The following is a description of a gene set: Any process that modulates the frequency, rate or extent of mitochondrial outer membrane permeabilization involved in apoptotic signaling pathway. species: Homo sapiens Human Gene Set: GOBP_REGULATION_OF_MITOCHONDRIAL_OUTER_MEMBRANE_PERMEABILIZATION_INVOLVED_IN_APOPTOTIC_SIGNALING_PATHWAY, and this is the list of marker genes: BOK, GCLC, GSK3A, SLC25A6, BCL2L1, SLC25A4, FZD9 (NCBI Gene Id 8326), TMEM14A, SIVA1, GSK3B, MPV17L, LRRK2, CHCHD10, ATP5IF1, SLC25A31, HSPA1A, ACAA2 (acetyl-CoA acyltransferase 2), IER3, MUL1, SLC35F6, BAK1, SLC25A5, ZNF205, HIP1R, TMEM102